Given this list of marker genes CCDC88A, SLC16A6, MKNK1, TNFRSF1A, SLC7A11, CEBPA (NCBI Gene Id 1050), ZFYVE21, PPA2, ACY1, NQO2, NCOR2, ISOC1 (NCBI Gene Id 51015), QPCT, MAN1A1, VDAC1, LAMP2, SMCO4, CLEC7A, FCER1G, SIRPA, GNS, PIR, LRP12, TOP1, TGFBI, BLVRA, NEU1, ZNF106, RRP1B, SOAT1, HCCS, PEA15, PGD, MTHFD2, MGST3 (NCBI Gene Id 9272), AREL1, EPAS1, TPM4, IFI30, CTDP1 (CTD phosphatase subunit 1), ANKRD17, SAMSN1, SRGN, TRPV2, HEBP1, MITF, PSMD1, FEZ2, HMOX1 (heme oxygenase 1), EPB41L3, SLCO2B1, SLC31A2, TMEM165, AKIP1, CDK5, NIBAN1, MGST2, BID, EHD4, SDC2 (NCBI Gene Id 6383), GLA, DCAF7, MPV17, TREM2, MAN2B1, EIF4G1, LEPROT, KDELR1, RHOG, PSMB5, MRPS14, KLF10, MAOA, ABR, ZMYM6, PLA2G7, RBM47, RTN3, RAPGEF2, SEPHS2, TM9SF1, PINK1 (NCBI Gene Id 65018), DENND1B, MRPL15, RCBTB2, RAP2B, ARRB2, TMCO1, YWHAH, PLAU, GLRX2, ETHE1, SAR1B, ATP6V1E1, SDHD, TPK1, MTMR6, CUX1, PLEKHB2, MAP7D1, GABARAPL1, APMAP, TM6SF1, PSMC1, DPYD, ARAP1, FTH1P5, SNAP29, FLVCR2, PLIN3, GAA, MAP1S (microtubule associated protein 1S), HSPA1A, LRRC59, ABHD6, MFAP1, RNF14, CD63, RTN4, CCDC47, SEC23B, GPX3, IDH2, VASH1, CITED2, TNFSF13, LST1, RIT1, ITGAM, HDLBP, RAD50, DOCK4 (NCBI Gene Id 9732), NCBP1, NRP1, TST, CD36, GPR137B, SLC25A44, TPI1 (triosephosphate isomerase 1), DNM1L, PCCB, SLC7A8, ZMIZ1, GCLC, RAP2A, ATP1B1, IMPDH1, DNAJB6, LGALS1, MAPKAPK3, MGAT1, TXNRD1, SYNJ1, TM9SF2, RHOC, ECPAS (Ecm29 proteasome adaptor and scaffold), ZNF267, EFHD2, ATXN1, ROGDI, CTNNA1, AIFM1, ZFYVE26, NPEPPS, LANCL2, DDB1, VCP, DPP3, PLXND1, PLBD1, RARS1, DSE, NAPA, JPT1, CD58, SNX1, IL7R, NRGN, GLS, PPIF, DGKZ, GRAMD4, SMC2, GSN, ADAP1, RREB1, VAMP3, ITFG1, TFG, FCGRT, MRPS15 (NCBI Gene Id 64960), SPINT1, TFEC, COMT, TIAM1 (NCBI Gene Id 7074), VPS37C, PLXNB2, PILRA, SEL1L, IMPA2, here is a description of the gene set: Immune cell-specific expression is one indication of the importance of a gene's role in the immune response. In order to identify such patterns, we set out to broadly profile gene expression in a variety of immune cells. species: Homo sapiens Human Gene Set: GSE22886_NAIVE_BCELL_VS_DC_DN from publication Abbas AR, Baldwin D, Ma Y, Ouyang W, Gurney A, Martin F, Fong S, van Lookeren Campagne M, Godowski P, Williams PM, Chan AC, Clark HF (PMID 15789058) Genes down-regulated in comparison of naive B cells versus unstimulated dendritic cells (DC).